Given this list of marker genes AVP, AVPR2, here is a description of the gene set: Arginine vasopressin (AVP(20-28)) is a 9 amino-acid long signal peptide produced by cleavage of the precursor protein AVP in the hypothalamus. It mediates the reabsorption of water in the kidney and its synthesis and release are physiologically regulated by plasma osmolarity, blood pressure and/or blood volume. AVP(20-28) binds to vasopressin receptors AVPR1 and 2, located on the basolateral surface of the kidney collecting duct. This binding results in interaction of AVPRs with the G protein alpha-s. Following a cascade of downstream events, ultimately the water channel aquaporin 2 (AQP2) translocates from intracellular stores to the apical surface where it functions as the entry site for water reabsorption. When water balance is achieved, plasma levels of AVP(20-28) drop and AQP2 levels in the apical plasma membrane are decreased.<br><br>Mutations in AVP make it unavailable to its AVPRs in the kidney, resulting in dysregulation of water reabsorption. This can cause familial neurohypophyseal diabetes insipidus (FNDI), an autosomal dominant disorder characterised by persistent excessive thirst resulting in constant drinking (polydipsia) and passage of large volumes of urine (polyuria). In FNDI, the production and release of AVP from the posterior pituitary gland is impaired. Reactome Pathway: Defective AVP does not bind AVPR2 and causes neurohypophyseal diabetes insipidus (NDI) studied in species Homo sapiens part of: SLC transporter disorders